Given this list of marker genes RECQL4, RPS3, BLM, OGG1, POT1, MSH3 (mutS homolog 3), MSH2, MUTYH, XRCC1, WRN, MSH6, here is a description of the gene set: Human Gene Set: GOMF_OXIDIZED_DNA_BINDING studied in species Homo sapiens Binding to a DNA region containing an oxidized residue.